The following is a description of a gene set: species: Homo sapiens The immune responses generated by YF-17D by profiling genes in 25 vaccine recipients were accessed at days 1, 3, 7, and 21 post-vaccination compared to pre-vaccination in PBMCs. The immune responses generated by YF-17D by profiling genes in 25 vaccine recipients were accessed at days 1, 3, 7, and 21 post-vaccination compared to pre-vaccination in PBMCs. Human Gene Set: GSE13485_DAY1_VS_DAY3_YF17D_VACCINE_PBMC_DN Genes down-regulated in comparison of unstimulated peripheral blood mononuclear cells (PBMC) 1 day after stimulation with YF17D vaccine versus PBMC 3 days after the stimulation. from publication Querec TD, Akondy RS, Lee EK, Cao W, Nakaya HI, Teuwen D, Pirani A, Gernert K, Deng J, Marzolf B, Kennedy K, Wu H, Bennouna S, Oluoch H, Miller J, Vencio RZ, Mulligan M, Aderem A, Ahmed R, Pulendran B (PMID 19029902), and this is the list of marker genes: TLR1, LIG4, ERI2, CCR1, STAT1, RPS2P45, BLOC1S6, FAM210A, MARCKS, ZCCHC9, FAM120AOS, CTNND1, KIN, FMNL2, ZNF106, GDPD1, FANCM, CHCHD3, ME2, ZSCAN16, HERC6 (NCBI Gene Id 55008), SCARB2, MPLKIP, FRS2, SNW1, RAD50, ACYP2, TLR7, LYSMD2 (NCBI Gene Id 256586), TUBD1, FAR2, TMEM65, SERPING1, HEBP1, SLC25A43, PPRC1, RBBP9, FBXO4, SGK3, GBP1, CCDC90B, CA5BP1, CTSC, SCLT1, OGFOD3, CD164, ATP11C, DDX60, RNF20, PHF11, CASP7, SGO2, PARPBP (PARP1 binding protein, NCBI Gene Id 55010), CASP1, ISG15, ZCCHC10, SNX14, IFI44L, C11orf54, NTAN1, IFITM1, SETD3, FBXO6, SUCLA2, DDX60L (NCBI Gene Id 91351), PPEF2, BCL10, RUNDC1, POLK, RNF170, GCH1, CD58, ABHD6, MVB12A, ODR4 (odr-4 GPCR localization factor homolog), MRPL50, CARD6, MRGBP, NCK1, RNF114, FANCL, THAP9, USP18, TCF7L2, IFIT5, CRNKL1, CCNYL1, IFIH1, HAVCR2, FAM241A, SECTM1, NT5C2 (5'-nucleotidase, cytosolic II), SLC25A12, PIGX, FERRY3, EXT2, LMBR1, ZMPSTE24, ATP6V0E1, PPP2R3C, DPH3, DESI2, XIAP, YIPF5, CLEC12A, PSMG1, GRSF1, APOBEC3A, EPSTI1, IFNAR1, NAA30, SMNDC1, UNC50, CRK, FNIP2, LAMP3, SIGLEC1, FH, BMP2K, VRK2, MRPS18B, CALML4, SETMAR, CLIC2, COG3, IFIT3, RBBP8, SEC24A, FAM98A, TAP1 (transporter 1, ATP binding cassette subfamily B member), SRBD1, DUSP6, MTF1, RSAD2, ADPRH, GINS1, CYP2U1, ZNF684, SLC31A2, CNDP2, RHEB, SAMD4A, TOR1B, TXNL1, ZNF410, CMPK2, TLR4, COPS5, AZI2, YARS2, TMX2, XAF1 (NCBI Gene Id 54739), TXNDC9 (NCBI Gene Id 10190), MRM2 (mitochondrial rRNA methyltransferase 2), CEP83, PARP9, METTL21A, SMC2, GMEB1, TMEM268, IFI44, PRPF4, BRAF, RFC5, FGD2, MSMO1, AURKA, PSME2, PI4K2B, CYP20A1, ABITRAM, PLSCR1, IL10RB, ZPR1, HYLS1, NMI, SLC31A1, SLFN12, CNOT8, SIDT2, MBOAT1, SCAMP1-AS1, ZNF30, WIPF2, TRIM69, CXorf38, TATDN3 (NCBI Gene Id 128387), RNFT1, CTSL, POP4, ZNF641, TMEM50B, KLHL12, RETREG2, IKBIP, NEDD9, BPNT1, DHX58, EIF2AK2